Given this list of marker genes AVIL, SCIN, DSTN, VILL, MYH9, CSRP3, GMFG, CFL1, SVIL, VIL1, CAPG, GSN, SRGAP2, GMFB, FMNL1, FLII, CFL2, here is a description of the gene set: species: Homo sapiens Human Gene Set: GOBP_ACTIN_FILAMENT_SEVERING The process in which an actin filament is broken down into smaller filaments.